The following is a description of a gene set: Human Gene Set: GSE12003_4D_VS_8D_CULTURE_MIR223_KO_BM_PROGENITOR_UP studied in species Homo sapiens from publication Baek D, Villén J, Shin C, Camargo FD, Gygi SP, Bartel DP (PMID 18668037) Genes up-regulated in of bone marrow progenitors with MIR223 knockout: 4- versus 8-day cultures. This array analysis is to study developmental time course of the regulation of target messages’ expression during culture of murine neutrophils versus miR-223 null neutrophils. Culture media was SILAC-IMDM for MS analysis., and this is the list of marker genes: QRFPR, POLE, SLCO2B1, OCLN (occludin), AMIGO1, EMILIN2, SACS, SNED1, MALL, FER1L4, PLXNB2, GRIN2B, ACVR2B, PLEKHG3, TMOD2, BRINP3, SNAP25, ATXN7L2, TMEM270, LANCL2, PRSS21, KCND2, PLXDC1, MIR191, GREM1, PRIMA1, SPAM1, ZSCAN5B, BSN (NCBI Gene Id 90068), COL4A3 (collagen type IV alpha 3 chain), ERBB4, PIGC, IL20RB, SYCP2L, SLC4A3, MTFR2, DYNLT4, LRRC2, MIR382, ARHGEF10, KLHDC7A, NKPD1, HAO2 (NCBI Gene Id 51544), MPDZ, FGF23, PALM, GALP, RNF185, APOC1, MIR376B, CKAP4, PLA2R1, FAM180A, CADM1, MCM7, SOX14, PDZD7, PRM1, ANTXR1, RPLP0, CPT1A, KCTD17, GPA33, PLEKHO2, LRRC10B, DHTKD1, ATP8B1, HHEX, PROK2, NYX, IGFBP1, CLSTN2, FABP9, IL36G, HIRIP3, DGCR6, CNTN1, SNHG11, LDAF1, CACNG4, EPGN, NUP210L, FFAR2, CNIH3, MIR497, GUCA1A, SNX31, PTPRT (NCBI Gene Id 11122), B3GNT7, DYRK4, NEUROD2, CHAT, CSPG4, SLC2A6, KCNA1, FERD3L, APC2, DNAJC5B, NIP7, DPF3, PLEKHA6, SH3RF2, CAPN10, AGO4, NAPSA, GMPR, FREM2, MVK, MARCKS, OGFRL1, LAPTM4B, CD177, DUS1L, CNGB3, S1PR2, CCL26, CAMP, HTR1B, LHB, HEBP2, GCNT2, CLEC2L, MAP3K6, SERPINB8, PRR5, SHROOM1, F13B, BST1, CNPY4, GRINA, TNFAIP2, CORO2B, NEGR1, GRIN2C, DCAF12L2, NFASC, CXCL1 (NCBI Gene Id 2919), LCN8, DPYSL4, RTL9, ALDH3B1, NAV3, MIR146B, TIMM17B, ITGB5, AIPL1, IHH, FBXO6, GHR, GLRA2, PTPRS, GPR156